Given this list of marker genes TRPC5, TRPC4, TRPM4, TRPC4AP, TRPC7, TRPV6, TRPV5, TRPM6, TRPM1, TRPM2, TRPA1, TRPC6, TRPV1, MCOLN3, MCOLN2, TRPM8 (transient receptor potential cation channel subfamily M member 8), TRPC3, TRPM7, TRPV4, MCOLN1, RIPK1, RIPK3, MLKL, TRPV2 (NCBI Gene Id 51393), TRPV3, TRPM5, TRPM3, TRPC1, here is a description of the gene set: Human Gene Set: REACTOME_TRP_CHANNELS TRP channels studied in species Homo sapiens